Given this list of marker genes CDS1, PITPNM3, CDIPT, PITPNM1, PITPNM2, here is a description of the gene set: Phosphatidylinositol (PI) is synthesized when phosphatidic acid (PA) and cytidine triphosphate (CTP) are converted into cytidine diphosphate-diacylglycerol (CDP-DAG) followed by conversion into PI and cytidine monophosphate (CMP). species: Homo sapiens part of: Glycerophospholipid biosynthesis Reactome Pathway: Synthesis of PI